Given this list of marker genes CTNNB1, RHO, RDH5, PRPH2, PRPF3, RLBP1, BRAF, here is a description of the gene set: Human Gene Set: HP_PROGRESSIVE_VISUAL_FIELD_DEFECTS Progressive visual field defects studied in species Homo sapiens